The following is a description of a gene set: Human Gene Set: HP_DISPROPORTIONATE_SHORT_LIMB_SHORT_STATURE A type of disproportionate short stature characterized by a short limbs but an average-sized trunk. Disproportionate short-limb short stature studied in species Homo sapiens, and this is the list of marker genes: COL2A1, COL1A2, ACAN, FGFR3, DYM, IFT122, HSPG2, TBX15, B3GAT3, PPIB, KYNU, POC1A, TRIP11, P3H1, TRPV4, SOX9 (SRY-box transcription factor 9), EVC, DDRGK1, SLC26A2, MATN3, FGFR1, TBK1, COMP, IHH, MESD, DDR2, PKDCC, KMT2A, HS2ST1, CRTAP, INPPL1, COL10A1, IFT52, PRKAR1A, WNT5A, FGFR2 (NCBI Gene Id 2263), GNPAT, GPX4, PRKG2, CANT1, RMRP, ALG12, XRCC4, SLC35D1, WDR35, MIR140, DYNC2I1, SLC39A8, DYNC2H1, CEP120, GSC, CSGALNACT1, COG1, PEX7, SHOX, PCYT1A, ALG9, DHCR24, GPC6, NSMCE2, GLI1, ROR2, CREB3L1, ARCN1, XYLT1, ALPL, TONSL, FLNB, BMPR1B (NCBI Gene Id 658), LBR, IFT43, SERPINH1, EXTL3, B3GLCT, DYNC2I2, WDR19, MTOR, CEP57, COL11A1, PRKACA, MMP13, HDAC6, CFAP410 (cilia and flagella associated protein 410), AGPS, SIK3, NPR2, FZD2, IFT80, DVL1, PRKACB, CHST3, GDF5, COL1A1, GNPNAT1, KDELR2, IFT140, KIAA0586, NXN, CSPP1, MAB21L2, KIAA0753 (NCBI Gene Id 9851), CLPB, MYSM1, CTSK, DYNC2LI1, DHCR7, PTH1R, EVC2, EBP, ASXL1, MBTPS2